Given this list of marker genes ABL1, MDM2, BBC3, MYC, PMAIP1, BAX, ATM, GADD45A, BOK, CDKN1A, TNFSF10, CDKN2A, TP73, BCL2, OTX2, TP53, TP63, BID, SUMO1, here is a description of the gene set: Human Gene Set: WP_TP53_NETWORK TP53 network species: Homo sapiens